The following is a description of a gene set: Human Gene Set: GOCC_NEURONAL_DENSE_CORE_VESICLE A dense core vesicle (granule) that is part of a neuron. These vesicles typically contain neuropeptides. They can be found in all parts of neurons, including the soma, dendrites, axonal swellings (varicosities) and synaptic terminals. studied in species Homo sapiens, and this is the list of marker genes: NPY (neuropeptide Y), STXBP5, AVP, PLCB2, PDYN, SYT5, VPS13A, FZD8, CHGA, HCRT, CADPS, NPFF, SST, KIF1A, OPRD1, SCG2, P2RX2 (purinergic receptor P2X 2), ADRB1, CALCA, PENK, GHRL, ADRB2, SYT4, DVL1, GNAI2, IGF1, CACNA2D1, APP, DMXL2, TAC1, OXT, CRH